The following is a description of a gene set: Mouse Gene Set: chr6G1 studied in species Mus musculus, and this is the list of marker genes: 1700051K13Rik, Gpr19, Eps8, Tas2r124, Gm18689, Gm5886, Gm30332, Dynlt1-ps1, Gm8956, Dera, Tas2r103, Mgst1, 4930480K02Rik, Gm44140, Tas2r145-ps3, Eif4a3l1, Mgp, Tas2r122, Gm5154, Gm18326, Gm18690, Etv6, Gm19434, Prb1c, Gsg1, Gm30055, Rerg, Borcs5, B230110G15Rik, A830011K09Rik, Gm34224, Tas2r123, Gm6375, Gm29803, Tas2r136, Lmo3, Tas2r117, Gm34391, Tas2r131, Smco3, Kap, Gm36582, Gm38910, H2aj, Apold1, Dusp16, Arhgdib, Gm26105, Ddx47, Strap, Gm9038, Crebl2, Gprc5d, Tas2r116, Gm5885, Gm34314, Gm22881, Gm34149, Rpl36a-ps3, Tas2r120, Prh1, Ube2q2l, 4930425L21Rik, Gm25136, Prb1a, Gm43979, BC049715, Art4, Gm25434, Gm17089, Grin2b, Tas2r110, Gm36328, Tas2r146-ps1, Erp27, Gm4714 (predicted gene 4714), Tas2r140, Gm6728, Pbp2, Gm15476, Tas2r109, Bcl2l14, Tas2r115, Lockd, Tas2r142-ps5, 4922502N22Rik, Tas2r121, 5530400C23Rik, Gprc5a, Prb1b, A630073D07Rik, Prp2, Tas2r125, Gucy2c, Gm7039, Gm18691, Hebp1, 2810454H06Rik, Gm36640, Gm44003, Tas2r102 (taste receptor, type 2, member 102), Mansc1, Gm14330, Tas2r111-ps2, Pde6h, Slc15a5, H4c16, Atf7ip, Ptpro, Gm26653, Gm14329, Fam234b, Tas2r113, Emp1, Wbp11, Tas2r129, Cdkn1b, Gm8921, Smim10l1, Tas2r141-ps4, Plbd1, 4933406J09Rik, Gm43978, Lrp6, Igbp1b